The following is a description of a gene set: species: Homo sapiens The multiplication or reproduction of epithelial cells, resulting in the expansion of a cell population that contributes to the progression of the prostate gland over time. Human Gene Set: GOBP_EPITHELIAL_CELL_PROLIFERATION_INVOLVED_IN_PROSTATE_GLAND_DEVELOPMENT, and this is the list of marker genes: SERPINF1, WDR77, CTNNB1, EAF2, AR, NKX3-1, CDKN1B, NOTCH1, SHH, STK11, SOX9